Given this list of marker genes SERTAD1, GAL, TBC1D14, ATF5, SPRED2, PCGF5, SMAD7, WBP1L, WWP2, F3, SMOX, TNFRSF12A, KLF7, B3GNT5, ARG1, UBXN4, IL7R, NT5E, LYAR, TNFAIP3, SF3A3, PPARD, SPP1, TP53I11, NFIL3, BLCAP, TEC, CHKB, CD80, IRS2, ZNF473, ACAT2, STS, WDR91, DDIT3, SLC16A3, XBP1, EPHA2, SLC9A5, EHBP1, SYCP2, APBB2, RHOV, HCAR2, UCK2, GCNT1, STX7, TUT7, CAV1, FXN, CSRNP1, ELK3 (NCBI Gene Id 2004), SCHIP1, ALDOC, ZFP36L1, CEBPB, GCH1, USP53 (ubiquitin specific peptidase 53), EDF1 (endothelial differentiation related factor 1), CAVIN1, ADRA1A, BEX3, PLA1A, PROCR, CCL4, CRTAM, MED7, SOD2, FLCN, CCDC97, CPED1, GPR25, SH3PXD2B, TPI1, ADAM8, ELL, SIX6, SPHK1, GPR137B, DAB2, TP53BP2, PRUNE2, B4GALT1, TREM1, RBMS1, F2RL2, ANGPT2, TLR2, RAB19, BEND6, ZNF76 (zinc finger protein 76), SDC4, MIF, RBM42, RESF1, KBTBD13, CYTIP, PNRC1, TNFAIP6, CXCL3, PRPS1L1 (NCBI Gene Id 91802), CD109, GPAT3, MAFK, NDRG1 (N-myc downstream regulated 1), HLA-B, PTGS2, TM4SF1, BZW2, ZMIZ1, DUSP4, DUSP6, CREB5, ANKRD37, HMGA2, ASB15, MAFF, ADAM28, SLCO4A1, ALDOA, ATXN7L1, SEC62, IL1B, GRINA, RNF149, NOTCH4, PMEPA1, NLRC5, ZNF18, MMP2, NFAT5, HAL, CSF1 (colony stimulating factor 1), CYLC2, SHFL, CDH1, CPSF7, ABCA1, BRI3, SLC2A1, FKBP11, CCRL2, MARF1, PAXBP1, MMP10, H1-4, ECHDC3, SLC15A3, TECPR1, NYX, APBB3, LDHA, SKI, LXN, MFSD4B, RPL39L, RBP7, MSH3, CYTH1, CTPS1, BASP1, EDN1, LDB2, DUSP16, TRPM8, ATP6V0A1, TRIB3, APOC3 (NCBI Gene Id 440838), CHD7, ETS2, TES, MYCN, HILPDA, EMILIN2, LGALS3, ARPP19, CXCL14, TESMIN, FZD2, PPP1R3G, MRTO4, AOPEP, KLHL25, AQP9, SLC25A33, FOSL1, EMCN, CHST1, OGA, CRABP1, SORBS1, WTAP, SCN5A, GPR19, CISH, SLC7A6OS (solute carrier family 7 member 6 opposite strand), BHLHE40, CDKN1A, UACA, AKR1B15, here is a description of the gene set: Human Gene Set: GSE3039_NKT_CELL_VS_B2_BCELL_DN Genes down-regulated in NKT cells versus B2 B lymphocytes. from publication Yamagata T, Benoist C, Mathis D (PMID 16623764) studied in species Homo sapiens Three innate (B1-B, NKT, CD8aaT cells) and adaptive (B2-B, CD4T, CD8abT cells) cell-types were sorted by FACS. Three biological replicates for NKT, CD4T, CD8aaT, CD8abT cells and two biological replicates for B1 and B2 cells were generated and the expression profiles were determined using Affymetrix Mu74Av2 chip. Comparisons between the sample groups allow the identification of genes differentially expressed between the innate and adaptive cell-types.